The following is a description of a gene set: The process that results in the patterns of cell differentiation that will arise in an embryo. Mouse Gene Set: GOBP_EMBRYONIC_PATTERN_SPECIFICATION studied in species Mus musculus, and this is the list of marker genes: Tifab, Tdrd1, Sema3f, Sema3a, Tmed2, Neurog1, Cobl, Bmp4, Tdrd5, Foxa2, Fzd5, Satb2, Shh, Lama5, Tbx6, Ripply1, Ooep, Disp1, Frs2, Zic3, Tbx3, Ihh, Fgf10, Nodal, Frat1, Fgfr2, Pld6, Tdrd7, Ctnnb1, Cripto, Gdf3, Nanog, Nog, Otx2, Lrp6, Cdx4, Chrd, Cdx2, Meis1, Pcsk6, Six1, Stil, Ripply2, Tdrkh, Zbtb16, Smad1, Meox2, Wt1, Meox1, Pgap1, Smad6, Smad2, Peg12, Ednra, Smad3, Wnt5a, C2cd3, Mesp2, Bmp7, Wnt1, Nrarp, Tcf7l1, Nrp2, Wnt7a, Lhx1, Efnb1, Chrdl1, Ripply3, Smad5, Kdm6a, Mesp1 (NCBI Gene Id 17292), Meis3, Sim2, Dop1b, Smad4 (NCBI Gene Id 28063), Dll1, Ptch1, Meis2, Tdrd6, Epb41l5, Erbb4, Tfap2a, Nckap1, Cdx1, Cited1, Nrp1, Tasor, Noto